Given this list of marker genes Axl, Ptk2, Xbp1, Calm1, Hcst, Fyn, Rasd2, Dab1, Insrr, Calm3, Calm2 (NCBI Gene Id 75700), Igf1r, Pik3r1, Ptpn13, Pik3ap1, Insr, Becn2 (beclin 2), Tlr4, Irs3, Tyro3, Jak2, Gsn, Fbxl2, Dab2ip, Cd2ap, Pdgfra, Lck (NCBI Gene Id 16818), Cbl, Fam83a, Irs1, Coro1a, Pdgfrb, Fam83b, Pik3r2, Becn1, Dnm2, Atp1a1, Irs2, Irs4, Nlrc3, Flt3, Met, Esr1, here is a description of the gene set: Binding to a phosphatidylinositol 3-kinase, any enzyme that catalyzes the addition of a phosphate group to an inositol lipid at the 3' position of the inositol ring. Mouse Gene Set: GOMF_PHOSPHATIDYLINOSITOL_3_KINASE_BINDING species: Mus musculus